Given this list of marker genes RXRA, MDH1 (NCBI Gene Id 4190), MNDA, PLIN3, SLC1A5, MPC1, AP2M1, SPTSSA, DOLK, DPYD, PPT1, CYFIP1, TUBA1B, ANXA5, IMPDH1, ANXA2P2, RAC1, LMO2, RAPGEF2, NQO1, CTSS, BID, BCKDK, PGAM1, RNASE6, CORO1C, LTBR, SYK, LAPTM4A, TBC1D12, CLASP2, TOR4A, PTGS1, HLA-DRB1, GABARAP, GPR137B, PSEN2, AP2S1, IDH1, RAB13, CD83, FTL, GRB2, SUOX, RNF130, S100A11, TUBB6, ZNF804A, SLC16A6, SPART, RAB11FIP1, ANXA2, ATP6V0B, CYREN, PLBD1, TOP1, PNPLA6, CYP51A1, HMGCR, LY96, KLHL2, CD63, NPTN, SLC7A8, TIAM1, JPT1, FCER2, SOAT1, HLA-DQA1, VDAC1, HCCS (holocytochrome c synthase), CTNNA1, DAB2, ETFA, ORAI3, DUSP3, IFI30, ITPRID2, CD58 (CD58 molecule), DLD, KIAA0930, CAPZA2, GNG10, HTT, HSBP1, ATP6V1F, HLA-DMB, ATPAF2, SNX13, NFKBIE, EGR2, ATP6V0E1, WSB2, NCSTN, CTSH, PLOD1, ATP6V1B2, ACO2 (NCBI Gene Id 50), CCDC47, CC2D1A, CAPRIN1, CREG1, ATP1B1, CST3, NAGA, SLC3A2, MTHFD2, RAB31, GLRX2, SLC31A2, CEBPA, PI4K2A, CLTA, WDFY3, ABHD6, ARHGEF11, FABP5, SPG21, FTH1P5, ZMIZ1, SH3TC1, CSNK2A1, CAT, FCER1G, GDE1, PLCG2, FLVCR2, RIT1, MAN2B1, FTH1, TRAPPC3, AP3B1, M6PR, POGK, RNH1, KCTD5, SERF2, MGST2, SYNGR2, SNX1, DAPK1, RCOR1, GCA, ARL8B, SLC11A2, LAMTOR3, CTSB, ATP6AP2, LAP3, FPGT, FEZ2, VAMP3, GNG5, RREB1, TUBA1C, ENTPD1, STAC, ZFYVE21, ATP6V1E1, GPX1, HHEX, PSEN1, RCBTB2, TGFBI, PSMB5, PCBD1, VIM, CCR1, SELENOT, TXN, TMEM70, SNX5, SLC4A2, CLEC7A, BASP1, VAMP8, CD74, HSPA4, HLA-DMA, GSN, TFG, MACROH2A1, TAX1BP3 (NCBI Gene Id 30851), DSE, TM6SF1, NDUFV2, SNX3, DCAF7, VPS41 (NCBI Gene Id 27072), GLUL, HOMER2, PGD, SNX2, MFSD1, TM9SF1, LAMP2, CRIM1, ATP6V1A, LST1, SMCO4, here is a description of the gene set: Immune cell-specific expression is one indication of the importance of a gene's role in the immune response. In order to identify such patterns, we set out to broadly profile gene expression in a variety of immune cells. Genes down-regulated in comparison of naive CD8 T cells versus unstimulated dendritic cells (DC). species: Homo sapiens from publication Abbas AR, Baldwin D, Ma Y, Ouyang W, Gurney A, Martin F, Fong S, van Lookeren Campagne M, Godowski P, Williams PM, Chan AC, Clark HF (PMID 15789058) Human Gene Set: GSE22886_NAIVE_CD8_TCELL_VS_DC_DN